The following is a description of a gene set: We identified Pparg as a major orchestrator of the phenotype of adipose-tissue resident regulatory T cells (VAT Tregs). To establish the role of Pparg in shaping the VAT Tregs gene profile and cell dynamics, Tregs from lymph nodes and visceral adipose tissue of mice sufficient and deficient of Pparg expression in Tregs were double sorted for microarray analysis. Genes up-regulated in lymph node from aged mice: T reg versus T conv. from publication Cipolletta D, Feuerer M, Li A, Kamei N, Lee J, Shoelson SE, Benoist C, Mathis D (PMID 22722857) studied in species Homo sapiens Human Gene Set: GSE37532_TREG_VS_TCONV_CD4_TCELL_FROM_LN_UP, and this is the list of marker genes: MRPS18B, MIF, TSR2, WDR75, NOP58, YDJC (NCBI Gene Id 150223), DBN1, EXO1 (NCBI Gene Id 9156), PLPP1, SFXN2, ALG3, TMEM147, USP39, POLR3E, ELP5, PRMT5 (NCBI Gene Id 415048), DTD1, WDR36, SLC7A5, TMEM109, METTL1, ZC3H15, NUDT9, ASH2L, EBNA1BP2, THUMPD1, PSMD12, EXOSC7, EXOSC2, TXNRD1, METTL13, CLUH, GAR1, C6orf136, POLR2I, FAH, MRTO4, SEPHS2, SAR1A, RSL1D1, HYOU1, WDR46, PRELID3B, TMEM216, UNG, SLC19A1, KYAT3, RYK, POLR1E, EEF1D, APRT, MFSD2A (MFSD2 lysolipid transporter A, lysophospholipid), FTSJ3, CFAP298, C19orf48P, NDUFAF4, CDC6, MIX23 (NCBI Gene Id 131076), TMA16, MCM8, HK2, PCGF6, YAE1, DANCR, RPP14, SURF6, SNHG32, HSP90B1, EBI3 (NCBI Gene Id 10148), ICAM1, RAB5IF, SURF2, PTPMT1, MFHAS1, WDR3, ZNF239, ZDHHC3, ADSL, C1QBP, CD70, FIGLA, TIMM10, DYM, NUP43, AEN, PSMG1, DNAJC2, LITAF, RBM8A, MAGOHB, GPATCH4, TRMT61A, CHCHD4, TTC27, SNRPA1, COQ4, DDT, EIF2B3, SAMD11, BSN, NOPCHAP1 (NCBI Gene Id 121053), SHQ1, CTPS1, PARN, CHD1L, PRDX6, MRPL37, SNHG17, DDX56, LAP3, SRP72, NRP2, TOP1MT, MRPS2, WDR55, BSPRY, SLPI, GPR89B, RIMKLA, SAA1, MCRIP2, ABCG2, NIFK, PLSCR1, C11orf58, SLC35F2, MTAP, CDC25A, ECE2, TIMM9, ECSIT, PAPOLA (poly(A) polymerase alpha), DNAH11, ALDH18A1, PSME3, SRM, IMPDH1, MRPS6, PUS7L, WDR74, MPHOSPH10, AHCYL1, GNAT2, PARL, CCND2, RARS1, HDGF (heparin binding growth factor), GRWD1, CCT3, POLR1B, CCT6A, RARS2, ATIC, NOP2, UTP4, PHGDH, PRAF2, SF3A2, ATAD3A, MTRES1, SLC35B2, PSMG2, NFIL3, LZIC, TNFRSF8, ABHD14A, TSEN2 (NCBI Gene Id 80756), AIMP2, MUC1, RCL1, TSR1, GNG3, CLNS1A, ENDOG, NOP14, DNAJC11, IRF4 (NCBI Gene Id 4592), IDO1, MRPS27, MMADHC, IDH3A, MED22, SHMT2, ACY1, SUPV3L1, ECI1, HSPD1, RRP1B, GART, PRMT1, C7orf50, SRP68, WDR77, C8orf76, PECR (peroxisomal trans-2-enoyl-CoA reductase), HTR7, CDH17, ZDHHC23, NOP56, DUS4L